Given this list of marker genes Bmp2, C5ar1, Stat3, Id4, Actr3, Vps54, Mag, Vim, Ror2 (NCBI Gene Id 26564), Map2k1, Plp1, Hes5, Ntrk3, Egfr, Prpf19, Ptpn11, Serpine2, Il1b, Gfap, Lamb2, Hes1, Abl2, Ager, Nr1d1, Gcm1, Lrp1, Pax6, Mapk3, Gpr37l1, Abl1, S100a9, Tlr4, Sox8, Clcf1, Nr2e1, Mecp2, Large1, Pou3f2, Lif, Mapk1, Trem2, Nog, Nfix, Smo, Gm5849, Bin1, Eif2b5, S100a8, Tspan2, Zeb2, Sox9, Kras, Nr3c1, Ttc21b, Plpp3, Dll3, Nkx2-2, Csf1r, Gap43, Ifng, Dll1, Qki, Fgfr3, Mfsd8, Ror1, Grn, App, Drd1, Vax1, Abcc1, Naglu, Tal1, Id2, Dab1, Cul4b, Cntf, Atf5, Lamc3, Psen1, Sox6, Il6st, Eomes, Epha4, Notch1, Ldlr, Cntn2, Shh, Hmga2, Mycn, Agt, F2, Nf1, Mbd1, Adora2a, Kdm4a, Ifngr1, C1qa, here is a description of the gene set: Mouse Gene Set: GOBP_ASTROCYTE_DIFFERENTIATION The process in which a relatively unspecialized cell acquires the specialized features of an astrocyte. An astrocyte is the most abundant type of glial cell. Astrocytes provide support for neurons and regulate the environment in which they function. studied in species Mus musculus